Given this list of marker genes EIF3A, EIF3G, EIF3CL, COPS5, EIF3C, EIF3M, EIF3J, EIF3F, EIF3B, EIF3L, EIF3E, DDX3X, EIF3I, EIF3H, EIF3K, EIF3D, here is a description of the gene set: Human Gene Set: GOCC_EUKARYOTIC_TRANSLATION_INITIATION_FACTOR_3_COMPLEX studied in species Homo sapiens A complex of several polypeptides that plays at least two important roles in protein synthesis: First, eIF3 binds to the 40S ribosome and facilitates loading of the Met-tRNA/eIF2.GTP ternary complex to form the 43S preinitiation complex. Subsequently, eIF3 apparently assists eIF4 in recruiting mRNAs to the 43S complex. The eIF3 complex contains five conserved core subunits, and may contain several additional proteins; the non-core subunits are thought to mediate association of the complex with specific sets of mRNAs.